The following is a description of a gene set: Human Gene Set: GOCC_MRNA_CLEAVAGE_AND_POLYADENYLATION_SPECIFICITY_FACTOR_COMPLEX studied in species Homo sapiens A multisubunit complex that binds to the canonical AAUAAA hexamer and to U-rich upstream sequence elements on the pre-mRNA, thereby stimulating the otherwise weakly active and nonspecific polymerase to elongate efficiently RNAs containing a poly(A) signal., and this is the list of marker genes: TUT1, SSU72L3, CPSF3, NUDT21, SSU72, CSNK1A1, SYMPK, CPSF6, SSU72L1, SSU72L6, CPSF2, SSU72L4, CPSF1, CSTF2T, PIP5K1A, CPSF7, WDR33 (WD repeat domain 33), SSU72L2, CPSF4L (NCBI Gene Id 651471), FIP1L1, ZC3H3, CSTF2, SSU72L5, CPSF4